Given this list of marker genes GDF3, POLG, PIK3CD, MECR, CHD7, OTX2, POLR3K, MAPKAPK5, RBL2, PEX19, TUBA8, CPLX1, DDX59, NDUFB3, NBAS, PEX6, CDON, MT-ND5, BEST1, NEDD4L, TMEM98, KAT6A, KCNA2, FKRP, CDK19, KIF11, PORCN, NUBPL (NCBI Gene Id 80224), SCYL1, TRIT1, KDM6A, CTNNB1, TUBB4A, FZD5, RP2, SNRNP200, ADAR, OTUD5, COL4A1, CEP290, ZFX, IDH3A, FAS, TMEM126B, FOXRED1, NOD2, PCARE, MPLKIP, ZSWIM6, TSC1, EPRS1, NFU1, SALL4, SRD5A3, SNF8, SOX2, TMEM107, POU1F1, TBCE, FBXO28, NOTCH3, PPP2R1A, ADAM22, MPDU1, EPCAM, MT-ND4, MTFMT (NCBI Gene Id 123263), PDSS1, COX7B, FRMPD4 (FERM and PDZ domain containing 4), TEFM, TRAF7, MYOC, RTN4IP1, XPA, PRPF4, TBC1D20, MID2, SIX6, DGUOK, ESPN, SLC6A9, DPYSL5, HK1, NLRP3 (NCBI Gene Id 9558), PIGA, FGFR1, TSC2, CASR, CEP85L, DARS1, NRL, ERF, EXOSC8, ATP5F1D (NCBI Gene Id 513), NFIX, SSBP1, SDHA, TMEM106B, TCTN2 (tectonic family member 2), ALG8, ZNF408, B3GALNT2, ERCC4, RPE65, ZIC1, MVK, BBS2, TK2, ARL13B, IFT74, RFX7, TACO1, CSF1R, MAK, EXOSC5, PACS2, TNFRSF11B, PTEN, POMT2, DNM1L, SH3TC2, P4HA2, AMPD2, ACTB, IL12A, DNMT3A, SDHD, ARL3 (NCBI Gene Id 403), CYFIP2, FBXL4, CASP2, GRN, CDHR1, NGLY1, SCAPER, GP1BA, RBP3, HIKESHI, SURF1, CNOT3, BRAT1, FZR1, CACNA1B, ACER3, TERT, DKC1, HUWE1, NR2F1, GLA, SPINT2, CACNA1C, FSCN2, RAX2, TSFM, ERCC8, SUMF1, GATA2, PTPN22, TRAPPC11, PIK3CA, WFS1, LYRM7, GGCX, TLR4, RNU7-1, NDUFS3, APOB, ATP5MK, PEX5, WWOX, HSD17B10, CKAP2L, MAFB, HLA-A, PEX2, IMPG1, ARL2BP, TIMM50, TBC1D24, PLXNA1, GJA1, PLAA, GLB1, SYNE1, ERCC3, PAX2, USP8, NDUFV1, DYRK1A, DHX38, DNMT1, KCNC2, BOLA3, ARNT2, TXN2, POGZ, DNAJC30, ZEB2, OPN1MW, ARHGEF18, IFT88, ELP1, PTPN23, MT-TW, DARS2, FDFT1, GEMIN4, SBF2, RP9, SLC19A2, RBMX, HESX1, CHN1, GATAD2B, COL18A1, C1QTNF5, KIZ, TNFSF11, FOXC1, ADA2, NDUFA6, CNGA3, RRAGC, SV2A, HCN1, RBP4 (NCBI Gene Id 5950), DDB2, MICU1, FLVCR1, FH, SLC30A9, WDR4, CCR1, MTO1, SP7 (NCBI Gene Id 121340), GSN, GLI2, SEMA4A, MT-TP, RERE, VRK1, TIMM8A, RLBP1 (NCBI Gene Id 6017), COA8, B3GALT6, MT-ND2, KMT2D, UBA5, NUS1, TMEM126A, MT-CO2, GRIA4, HLA-DRB1, B4GAT1, GUCY2D, KIF5A, DPYD, LCA5, MC1R, TBC1D7, GNAT1, SYNGAP1, EPG5, NDUFAF5, NALCN, ARVCF, IBA57, B9D1, MTSS2, GFM2, NEU1, XYLT2, PEX12, SAG, DNM1, BRAF, LZTR1, SAMD7, SLC52A2, PDE6A (phosphodiesterase 6A), TWNK, POMGNT2, POMGNT1, GP1BB, AHI1, ATF6 (NCBI Gene Id 22926), FAM111A, TUBGCP6, NSD2, NRCAM, NDUFS1, FREM1, RNF216, GALC, MT-ND4L, CACNA2D4, NUP54, PEX1 (NCBI Gene Id 7788), AP3B2, CLTC, TMEM63A, JAM3, DNAJC19, ERCC1, PCSK9, PEX3, NDUFB11, APC, POLR1A, FGFR2, YME1L1, NDUFS2, GABRD, LRP4, IL11RA, CACNA1F, ACADS, PNPLA6, SPG7, PRICKLE3, CTNNA2, SZT2, SLC38A3, RBM10, ANTXR1, MT-TL1, ELP4 (NCBI Gene Id 54515), RAB18, POMT1 (protein O-mannosyltransferase 1), ASPA, RTTN, ZNF513, MACF1, CRX, TMEM216, RP1, KIF14, RNF170, TMTC3, ALMS1, KLHL7, TMEM222, IL23R, GLRX5, VCAN, FAM161A, CLCN2, ARHGEF2, CFAP410, ATRX, UCHL1, ATP1A3, FA2H (fatty acid 2-hydroxylase), RREB1, NUP62, ITM2B, CASK, SPEN, GDF6, FDX2, MT-CYB, BBS1, WDR11, AIPL1, PRDM16, AUH, DALRD3, NMNAT1, PEX14, ARSA, PTF1A, CLCN7, RHO, GBA1, MAN2B1, PCYT1A, STAMBP, TNFRSF11A, FKTN, OPA1, ROM1, AASS, CPAMD8, ARMC9, HMBS, PPP1R21, TRIM44, CNKSR2, NDUFC2 (NADH:ubiquinone oxidoreductase subunit C2), KCTD7, ABCG8, SOX3, TCIRG1, IDH3B, LHX3, SCN8A, INTS11, ATIC (5-aminoimidazole-4-carboxamide ribonucleotide formyltransferase/IMP cyclohydrolase), RPS6KA3 (NCBI Gene Id 6197), HLA-B, PERCC1, UFD1, DHDDS, KCNJ13 (potassium inwardly rectifying channel subfamily J member 13), NAA10, SPATA7, NDUFA1, NDUFS4, FANCB, UBE3B, ACTL6B, MRPS34, SUFU, DNA2, SETD2, RECQL4, GMPPA (GDP-mannose pyrophosphorylase A), PRORP, FGF12, LUZP1, CTC1, CCDC22, TANGO2, YWHAG, MKS1, STT3B, COMT, PROP1, IQCB1, PRPF3, ACO2, EXOSC3, P4HTM, TYRP1, CA4, MMP23B, MTHFR, RAB3GAP2, CFAP418, ASNS, MT-TN, LETM1, MT-ATP8, CYP27A1, ABHD12, KLRC4, NDP (NCBI Gene Id 4693), POLR3A, NDUFA11, CACNA2D1 (NCBI Gene Id 781), ADAM9, ELOVL1, MFF, KNSTRN, LDLR, MTPAP, NEK2, ERAP1 (endoplasmic reticulum aminopeptidase 1), PPT1, CA2, C2CD3, KIDINS220, PRPF31, MT-ND1, OPA3, TRRAP, MOGS, HNRNPK, TSEN54, MT-ATP6, BLOC1S3, AGTPBP1, ATXN1, RGR, SLC45A2, PANK2, CNGB1, PDPN, OFD1, MAP2K1, POMK, ASXL1, KLC2, PCYT2, PRPS1, PEX13, SLC13A5, MMACHC, SPTAN1, PROM1, RDH12 (retinol dehydrogenase 12), CBS, LDLRAP1, CISD2, CNNM4, SERAC1, NR3C1, TSPAN12, RPGRIP1, PIGB, MSTO1, TYR, PEX26, AP4M1, AGXT (alanine--glyoxylate aminotransferase), MT-CO1, RNF113A, OPN1LW, MFRP, TRAK1, PEX16, ABCA4, ARSL, SLC1A2 (NCBI Gene Id 6506), SCN3A, WNT3, RXYLT1, UBAC2, GABRA2, GATA3, RAB28, ATP5F1E (ATP synthase F1 subunit epsilon), ZPR1, JMJD1C, NADK2, LHX4, ARL6, MCAT, SLC7A14, CLN8, IDS, BCOR, TBX1, ABCG5, ALG13, MMP14, MT-ND6, SOX5 (SRY-box transcription factor 5), HNRNPU, PPP3CA, CLCC1, PISD, LAMB1, CLCN3, GPAA1, TOR1A, PDE6B, PDE6G, LRAT (NCBI Gene Id 9227), EMC1, PI4KA, PDXK, RAB11B, PAX6, MMP19, RPGR, KIF7, MINPP1, XPC (NCBI Gene Id 7508), BCAP31, SPOP, KCNB1, AFG3L2, TCTN1, MCOLN1, SEC24C, RNU4-2, RAB23, TUBB3, UQCRFS1, ALG3, FCSK, NAGA (NCBI Gene Id 4668), PRPH2, NDUFAF2, KIAA0586, AGBL5, KIAA1549, CRB1, VPS13B, UNC119, MYO5A, HSPG2, CLRN1, GABRA5, HIRA, CDH23, NARS2, POU3F4, GTPBP2, TEK, TTLL5, NIPBL, ST3GAL5, RPIA, GLYCTK (NCBI Gene Id 132158), NDUFA13, VSX1, TCTN3 (NCBI Gene Id 26123), SMO, SCN1A, INTS8, RIMS2, PRMT7, GMPPB, PDHX (NCBI Gene Id 8050, pyruvate dehydrogenase complex component X), ISCA2, TPI1, TLR7, ACTG1, DPAGT1, LRP5, VPS35L, SKI, ATP1A2, YAP1, POC1B, NDUFS8, GUCA1A, RPGRIP1L, ABCC6, TBCD, ACOX1, CASZ1, EIF4A2, AHR, PHOX2A, IFT172, PIEZO2, SNX10 (NCBI Gene Id 29887), SMARCB1, LARGE1, PPP1CB, GABBR2, GPR161, PROKR2 (prokineticin receptor 2), TLCD3B, AARS1, MMUT, ATP6V1B2, MGP, FXN, DENND5A, FDXR, USP45, PLK4, IFNGR1, NDUFS7, COG6, CDC42BPB, USH2A, ZNHIT3, GUCA1B, BAP1, DOCK6, POLG2, FLRT1, FOXE3, IL12A-AS1, NDUFAF3, IKBKG, KIF1A (kinesin family member 1A), ATG7, SYNJ1, TUBGCP2, IMPDH1, RSPO2, UBE4B, HHAT, IER3IP1, NTRK2, TASP1, C4A, MT-TH, RD3, SLC38A8, EIF2B2, ALDH1A3, BTD, RIMS1, TWIST1, TUBB2B, ATPAF2, ASB10, INPP5E, MFN2, TRNT1, TIMMDC1, DPM2, SLC4A2, IFT140, MT-TF, PRUNE1, PLP1, NDUFB9, TP53, CLN3, EIF2B1, CCDC88A, SLC39A14, FZD4 (frizzled class receptor 4), NDUFB10, SIL1, MED12, EYS, COL25A1, FGFR3, WT1, TRAPPC12, SLC25A46, GABRG2, TUBA1A, PIGG, MEFV, DDHD2, NR2E3, CENPF, SOST, STX3, SLC29A3, CHSY1, MAP2K2, SLC44A1, FOXG1, PRPF8, TGFB1, RNF135, PRKAR1A, C19orf12, DIAPH1, CLDN11, NDE1, ANKRD11 (NCBI Gene Id 92821), CC2D2A, ATN1 (atrophin 1), TMEM231, HMX1, MT-TK, B3GLCT, TMEM67, MT-TS2, VPS41, TBX4, PITPNM3, VPS53, NECAP1, CCND1, HGSNAT, KANSL1, PCLO, PIGU, TULP1, MIEF1, NDUFS6, IGBP1, MERTK, PARS2, CRPPA, CDC42, SEMA3E, SEC31A, ERCC6, DAG1, TUB, LAMB2, MT-TV, TBC1D2B, AFF4, EEF1A2, PLEKHM1, ATP6V1A, KRAS, TXNDC15, SMCHD1, XYLT1, WDR73, ZNF592, RHOA, KCNAB2, TMEM53, PSAP, SCYL2, IL10, OCA2, MPDZ, THG1L, HNRNPH1, RFC1, NDUFAF8, MAG, KCNK4, PCK1, DHCR7, MTOR (NCBI Gene Id 2476), TUBB4B, ATAD3A, NEFL, MEF2C, BBS5, POLR3B, GABRB2, TTC8, GRIN2D, VPS11, KIF21A, MMP2, NDUFAF1, PMPCB, FOXA2, RAB3GAP1, NDUFAF4, GNA11, ATP5F1A, EXOC2, CNGA1, NDUFV2, ANKH, GNAQ, MT-ND3, CACNA1A, RP1L1, KCNC3, CPSF3, USP48 (NCBI Gene Id 84845), SNAP29, ROBO1, REEP6 (receptor accessory protein 6), NT5C2, EXOC8, MBTPS2, OSTM1, PRKCZ, ARX, DPM1, SMG8, MT-CO3, CYP7B1, GRID2, DDX11 (DEAD/H-box helicase 11), IMPG2, VHL, HARS1, CYP1B1, TMEM237, GNPAT, GABBR1, SMOC1, CLP1, PRCD (NCBI Gene Id 768206), NF2, TOE1, CDH11, PEX10, MICOS13, EIF2B4, AAAS, ATXN7, FANCI, MFSD8, SEC23A, VPS33A, MT-RNR1, SARDH, EFEMP1, PDGFB, AP1S2 (NCBI Gene Id 8905), IFT43, STAG2, WDR45, RRM2B, NOTCH2NLC, TUBGCP4, CTLA4, CTBP1, AKT3, AKT1, SELENOI, AIFM1, ERCC2, ERCC5, PEX11B, B9D2, MAB21L1, ALDH1A2, PLA2G6, PRPF6, SLC25A19, PTCD3, MT-TQ, SMARCE1, WARS2, NELFA (NCBI Gene Id 7469), L2HGDH, MTRFR, CSPP1, SON, CELF2, PUF60, SALL2, TOPORS, EXOSC9, GJC2, SH3BP2, WASHC5, TFG, DRAM2, CERKL, STAT4, here is a description of the gene set: Human Gene Set: HP_ABNORMAL_OPTIC_NERVE_MORPHOLOGY studied in species Homo sapiens Abnormal optic nerve morphology Abnormality of the optic nerve.